The following is a description of a gene set: species: Homo sapiens A process in which force is generated within tonic smooth muscle tissue, resulting in a change in muscle geometry. Force generation involves a chemo-mechanical energy conversion step that is carried out by the actin/myosin complex activity, which generates force through ATP hydrolysis. In the tonic smooth muscle, the muscle contraction occurs without an ordered sarcomeric structure. Tonic smooth muscle contraction occurs as a sustained continuous contraction. Human Gene Set: GOBP_TONIC_SMOOTH_MUSCLE_CONTRACTION, and this is the list of marker genes: NMU, HTR2A, EDN2, SCNN1B, EDNRA, MKKS, CD38, BBS2, GRIP2, EDN1, MYLK, EDN3